Given this list of marker genes MRFAP1L1, IFT22, TRAM1L1, THAP7, PRICKLE1, LINGO1, ZNF397, MPP1, TNFAIP6, USP14, SERF2, GEMIN2, SLC17A3, TUB, MTERF4, PGF, MYCN, RGS20 (regulator of G protein signaling 20), SNRPD3, SLC22A6, S100G, TBC1D20, RNF17, SUV39H2, MRM1, SLC16A2, MXD4, RBMS2, SNX10, NHSL2, KMT5B, OLFML3, PSMD4 (proteasome 26S subunit ubiquitin receptor, non-ATPase 4), CIMAP1A, WASF1, QRICH1, PNPT1, PI16, ORMDL2, SLIT3, MAL, RPGRIP1, SECISBP2, MYO6, PHKG2, MYB, SRPK1, NPY2R (neuropeptide Y receptor Y2), PSMB1, GPR182, MFSD4A, ELOC, NRIP1, WFDC1, SPIRE2, STIMATE, STX1A, RHOBTB2, MYCT1, RPF2, SLC4A1, KIF3B, MYF5, SLC22A7, TBL1X, TNS2, PTPN4, ZNF334, P2RX4, TBCB, TTL, TAGLN2, RAD51B, TOMM7, RRM1, STMN3, RDH16, OTP, KRT13, PTPRU, MRRF, TC2N, SIAH1, NAPB, PAFAH1B2, TSPYL4, SOD3, ONECUT3, ORAI1, KRT32, MMP17, PTDSS2, SELENOK, ICE2, LTC4S, SNX15 (sorting nexin 15), PNMT, SOX4, VCAM1, SPESP1, TMEM50B, TMEM39A, YWHAE, ZIC1, MUTYH, MIDN, MAN2C1, NRM, PMS2, SELENBP1, SEPTIN4, RHBDD3, TECTB, NDUFB2 (NADH:ubiquinone oxidoreductase subunit B2), RALGPS2, TFAP2B, SATB2, PUS3, TMEM176A, PFDN2, YPEL3, RPS27L, TSNAXIP1, MYL9, LAMA2, UPK3A, ZNF207, LY6G6C, VPS37B, RNPS1 (NCBI Gene Id 10921), SYCP3, RAD23B, PTN, RCBTB1, NHERF2, PAX3, TOR1A, MKLN1, TSPY1, WDR54, SYNRG (NCBI Gene Id 11276), MSRB2, SEMA4F (NCBI Gene Id 9408), PANK3, MAN1B1, ZNF639, MOS, TNFSF13B, KPNA6, MIIP, SYNGR2, TP53INP1, SLC25A53, SYTL2, YARS1, LAPTM5, SHARPIN, PREB, OSBPL6, TAL2, TRPC6, WIPI1, TOX, TOR1B, WDR4, TXNDC9, L2HGDH, TNFSF4, LIPT1, RRP12, SHH, RGS4, MTF1, UROC1, STIL, PSMG4, YKT6, UCKL1, PGR, VAX2, UGGT2, VASN, CPQ, ZNF821, PTGES, MMEL1, SLC27A1, MMP1, SH3D19, SYT12, SIX4, MID2, RYK, SOX5, NCAM1, PIP4K2A, SCGN, TRMT1, SLC34A2, here is a description of the gene set: from publication Amit I, Garber M, Chevrier N, Leite AP, Donner Y, Eisenhaure T, Guttman M, Grenier JK, Li W, Zuk O, Schubert LA, Birditt B, Shay T, Goren A, Zhang X, Smith Z, Deering R, McDonald RC, Cabili M, Bernstein BE, Rinn JL, Meissner A, Root DE, Hacohen N, Regev A (PMID 19729616) Human Gene Set: GSE17721_LPS_VS_POLYIC_0.5H_BMDC_DN mouse primary BMDCs were stimulated with tlr ligands and gene expression changes were profiled on Affymetrix arrays studied in species Homo sapiens Genes down-regulated in comparison of dendritic cells (DC) stimulated with LPS (TLR4 agonist) at 0.5 h versus DC cells stimulated with poly(I:C) (TLR3 agonist) at 0.5 h.